Given this list of marker genes ZCCHC8, TGS1, PARN, TENT4B, TERC, here is a description of the gene set: Human Gene Set: KEGG_MEDICUS_REFERENCE_TELOMERASE_RNA_MATURATION species: Homo sapiens Pathway Definition from KEGG: TERC+TGS1 -> TERC+PAPD5 -> TERC+PARN+ZCCHC8 Telomerase RNA maturation. Pathway ID: N01475. Pathway type: Reference. Pathway class: nt06510 Telomere length regulation.